Given this list of marker genes POLD1, POLDIP2, POLE2 (DNA polymerase epsilon 2, accessory subunit), FAAP20, USP10, MAD2L2, POLH, PCNA, PRIMPOL, POLD3, PCLAF, POLN, DTL, USP1, VCP, POLI, SPRTN, PARP10, POLK, ZBTB1, POLD2, REV1, USP43, RCHY1, REV3L, POLQ, here is a description of the gene set: Human Gene Set: GOBP_TRANSLESION_SYNTHESIS species: Homo sapiens The replication of damaged DNA by synthesis across a lesion in the template strand; a specialized DNA polymerase or replication complex inserts a defined nucleotide across from the lesion which allows DNA synthesis to continue beyond the lesion. This process can be mutagenic depending on the damaged nucleotide and the inserted nucleotide.